The following is a description of a gene set: from publication Mikkelsen TS, Ku M, Jaffe DB, Issac B, Lieberman E, Giannoukos G, Alvarez P, Brockman W, Kim TK, Koche RP, Lee W, Mendenhall E, O'Donovan A, Presser A, Russ C, Xie X, Meissner A, Wernig M, Jaenisch R, Nusbaum C, Lander ES, Bernstein BE (PMID 17603471) Genes with intermediate-CpG-density promoters (ICP) bearing histone H3 trimethylation mark at K27 (H3K27me3) in neural progenitor cells (NPC). We report the application of single-molecule-based sequencing technology for high-throughput profiling of histone modifications in mammalian cells. By obtaining over four billion bases of sequence from chromatin immunoprecipitated DNA, we generated genome-wide chromatin-state maps of mouse embryonic stem cells, neural progenitor cells and embryonic fibroblasts. We find that lysine 4 and lysine 27 trimethylation effectively discriminates genes that are expressed, poised for expression, or stably repressed, and therefore reflect cell state and lineage potential. Lysine 36 trimethylation marks primary coding and non-coding transcripts, facilitating gene annotation. Trimethylation of lysine 9 and lysine 20 is detected at satellite, telomeric and active long-terminal repeats, and can spread into proximal unique sequences. Lysine 4 and lysine 9 trimethylation marks imprinting control regions. Finally, we show that chromatin state can be read in an allele-specific manner by using single nucleotide polymorphisms. This study provides a framework for the application of comprehensive chromatin profiling towards characterization of diverse mammalian cell populations. Human Gene Set: MIKKELSEN_NPC_ICP_WITH_H3K27ME3 studied in species Mus musculus, and this is the list of marker genes: CFAP65, PVALB, ESRP1, MLPH, ISLR2, RGS8, HOXB13, TTLL6, FXYD7, MATN1, POU2AF1, LIN28B